The following is a description of a gene set: from publication Bedogni F, Hevner RF (PMID 34321999) species: Mus musculus Mouse Gene Set: HEVNER_CORTEX_PROLIFERATING_CELLS Genes selectively expressed by proliferating cells and promote proliferation in embryonic day 14.5 mouse cortex., and this is the list of marker genes: E2f1, Mcm10, Bub1b, Foxm1, Ccnb1, Mcm2, Nuf2 (NUF2, NDC80 kinetochore complex component), Plk1, Mybl2, Mcm4, Hat1, Top2a, Nde1, Nusap1, Aurka, Shcbp1, Mcm7, Mcm3, Bub1, Gmnn, Slbp, Ccne1, Mcm6, Mcm5, Mki67